Given this list of marker genes Htatip2, Trp63, Eef1e1, Becn1, Hmgn1, Smarcb1, Asxl1, Trp73, Fgf9, Ssbp2, Nf2, Hic1, Tnk1, Pten, Wwox, Prdx1, Cdkn1a, Dkc1, Tiam1, Tgfbi, Taf4 (TATA-box binding protein associated factor 4), here is a description of the gene set: Mouse Gene Set: MP_INCREASED_MALIGNANT_TUMOR_INCIDENCE Mouse genes annotated to increased malignant tumor incidence (MP:0002018) retrieved from the Mouse Genome Informatics database via MouseMine from publication Motenko H, Neuhauser SB, O'Keefe M, Richardson JE (PMID 26092688) species: Mus musculus